The following is a description of a gene set: Enables the transfer of succinate, the dianion of ethane dicarboxylic acid, from one side of a membrane to the other. Human Gene Set: GOMF_SUCCINATE_TRANSMEMBRANE_TRANSPORTER_ACTIVITY species: Homo sapiens, and this is the list of marker genes: SLC13A3, SLC25A10, SLC13A2, SLC13A5 (solute carrier family 13 member 5), SLC16A1